The following is a description of a gene set: studied in species Mus musculus Reactome Pathway: Plasma lipoprotein remodeling part of: Plasma lipoprotein assembly, remodeling, and clearance This event has been computationally inferred from an event that has been demonstrated in another species.<p>The inference is based on the homology mapping from PANTHER. Briefly, reactions for which all involved PhysicalEntities (in input, output and catalyst) have a mapped orthologue/paralogue (for complexes at least 75% of components must have a mapping) are inferred to the other species. electronically inferred by orthology from the curated human pathway, and this is the list of marker genes: Alb, Angptl3, Lmf1, Apob, Gpihbp1, Pcsk5, Apoa5, Apoc2, Pltp, Apoa2, Angptl4, P4hb, Apoc3, Apoa1, Lipc, Apoa4, Abcg1, Lpl, Apoe